The following is a description of a gene set: Binding to a purine deoxyribonucleotide, any compound consisting of a purine deoxyribonucleoside that is esterified with (ortho)phosphate or an oligophosphate at any hydroxyl group on the deoxyribose moiety. studied in species Mus musculus Mouse Gene Set: GOMF_PURINE_DEOXYRIBONUCLEOTIDE_BINDING, and this is the list of marker genes: H1f4, Hsp90aa1, Samhd1 (SAM domain and HD domain, 1), St13, Trex1, Hsp90ab1